The following is a description of a gene set: Human Gene Set: HP_OLIGOSACCHARIDURIA Increased urinary excretion of oligosaccharides (low molecular weight carbohydrate chains composed of at least three monosaccharide subunits), derived from a partial degradation of glycoproteins. Oligosacchariduria studied in species Homo sapiens, and this is the list of marker genes: NEU1, HEXB, FUCA1, SLC35C1, GNPTAB, MANBA, GAA, GLB1, MAN2B1, OCRL, SNX14